Given this list of marker genes TNFSF11, PLEKHM1, IAPP, IL6, SRC, SYK, NF1, ADAM8, INPP5D, SUCO, BGLAP, ARAP1, SLC4A2 (NCBI Gene Id 96677), GREM1, MC4R, SPP1, PRKCA, SFRP1, CD38, PDK4, CLDN18, LEPR, IL20RA, GPR137B, CARTPT, MDK, FSHR, FSHB, TMEM119, CALCA, SIGLEC15, GPR137, P2RX7, TMEM64, DEF8, S1PR1, DCSTAMP, ITGB3, CSK, SYT7, RUFY4, TNFRSF11A, TNFAIP3, CSF1R, LEP, LTBP3, UBASH3B, here is a description of the gene set: Human Gene Set: GOBP_REGULATION_OF_BONE_REMODELING species: Homo sapiens Any process that modulates the frequency, rate or extent of bone remodeling, the processes of bone formation and resorption that combine to maintain skeletal integrity.